The following is a description of a gene set: from publication Napolitani G, Rinaldi A, Bertoni F, Sallusto F, Lanzavecchia A (PMID 15995707) Genes up-regulated in comparison of dendritic cells (DC) stimulated with R848 at 8 h versus DCs stimulated with LPS (TLR4 agonist) for 8 h. Human Gene Set: GSE2706_R848_VS_LPS_8H_STIM_DC_UP species: Homo sapiens Toll like receptors (TLRs) sense microbial products and initiate adaptive immune responses by activating dendritic cells (DCs). Since pathogens may contain several agonists we asked whether different TLRs may synergize in DC activation. We report that in human and mouse DC TLR3 or TLR4 potently synergize with TLR7, TLR8 or TLR9 in the induction of selected cytokine genes. Upon synergistic stimulation, IL-12, IL-23 and Delta-4 are induced at levels 50-100 fold higher than those induced by optimal concentrations of single agonists, leading to enhanced and sustained TH1 polarizing capacity. Using microarray analysis we show that only 1.5% of the transcripts induced by single TLR agonists are synergistically regulated by combinations of TLR4 and TLR8 agonists. These results identify a combinatorial code by which DCs discriminate pathogens and provide (suggest) a rationale to design adjuvants for TH1 responses. Series_overall_design: 3 untreated, 3 treated with LPS at 2h, 3 treated with LPS at 8h, 3 treated with R848 at 2h, 3 treated with R848 at 8h, 3 treated with LPS + R848 at 2h, 3 treated with LPS + R848 at 8h, and this is the list of marker genes: ARHGEF25, P2RX6, PRPF40B, BTG2, KAAG1, RIT2, CCNT2-AS1, PHYHD1, PLEKHA3, FILNC1, AQP4-AS1, LINC01107, DNAJB7, CNN1, PTPRH, ITPKB, CASKIN2, TSC22D1-AS1, MSRB2, CST5, SLC35C1 (solute carrier family 35 member C1), SH3GLB2, GPR160, DTD2, GKN2, ADD3, SOD3 (superoxide dismutase 3), IAPP, SPRR2C, AMPD1, FAM20B, DNAJB13, LAIR2, ARHGAP24, KLHDC8A, ARHGDIG, SAMD10, PKDCC, NPHS1 (NPHS1 adhesion molecule, nephrin), PIM2, SMIM14, ARL4D, ZSCAN16-AS1, VSIG4, GLB1L3, UHRF1, LHX2, ARSF, NOTCH3, LARGE-AS1, RRS1-DT, TESC, PDILT, PRKCA, PAK6, PAICS, FAM86C1P, TMEM243, CYP1A1, FTCDNL1, PHLDB3, RNASE11, NATD1, RTBDN, PGBD4, OPN3, IKBIP, B3GALT5, IRGC, DDX11L2, ZNF471, S100A1, FAM210A, DPYSL3, LMTK2, GPR18, ZNF229, MPEG1, FXYD1, TAFA5, SORT1, MYC, ONECUT1, SCNN1D, CYB5RL, PSG7, ERVFRD-1, CAPN8, ZNRF4, NAV2-AS5, DGKH, NOP16, MAP1B, SLC9A3-AS1, CBX7, CFAP96, IKZF1, TIMM21, MAGI2-AS3, ZNF205, MAF, ANKRD33, FMO4, HNMT, REG1A (regenerating family member 1 alpha), RPP40, LINC01281, GZMM, ZC3H8, REXO1L1P, LINC01018, NAGK, PLCD1, NEFH, ZNF112, MYOT, TSPAN8, LCE3D, MMACHC, FOS, FAM221B, ENTPD1-AS1, C2CD4B, RPS6KL1, TRHDE-AS1, LINC02685, GABRD, SIAH3, ARHGAP4, ITPR1, S1PR5, SEZ6L, SDC2, KIR3DS1, DANCR, FAM201A, DDX51, ADORA3, ABCC12, WFIKKN2, LHFPL4, CIB4 (NCBI Gene Id 130106), ZBTB9, CDH26, CELF4, SLIT1-AS1, CYP27A1, TOLLIP-DT, F2RL3, SLC5A1, VSTM2A, GPR101, SLC1A5, PRSS59P (serine protease 59, pseudogene), SMIM17, PSAT1, JARID2, PCDHB11, CELA2A, CFAP69, ATL2, OR7E19P, BAIAP2-DT, ZNF620, CD5L, CYTH3, CARD10, NRAD1, GHR, UTP4, DNAI7, LACC1, CACNA2D4, APCDD1L-DT, BRS3, THBS1, H2BW2, C3orf33, MYADML2 (NCBI Gene Id 652040), TBC1D8, SUV39H1, PGLYRP2, TPO, B3GNT8, SVIL, KRT33B, FAM106A